The following is a description of a gene set: species: Mus musculus Any process leading to the attainment of the full functional capacity of a protein. Mouse Gene Set: GOBP_PROTEIN_MATURATION, and this is the list of marker genes: Thbs1, Klk13, Hspa8, Aasdhppt, Mme, Hspe1-rs1, Cpa3, Pfdn1 (prefoldin 1), Astl, Lias, Cuzd1, Fnta, Srgn, Fkbp8 (NCBI Gene Id 14232, FK506 binding protein 8), Lonp2, Pgap3, Atg4d, Prcp, Casp6, Prkacb, Ppic, Rnf123, Sec11a, Bag1, Hspb2, Ppp1r15a, Klk1b27, Usp17le, Snx12 (NCBI Gene Id 72081), Glrx3, Klk5, Slc30a8, Hsph1, Erp27, Prss57, Psenen, Plaur, Klk1b21 (NCBI Gene Id 16616), Tbcel (tubulin folding cofactor E-like), Fgg (NCBI Gene Id 99571), Dnajb4, Klk1b16, Ren1, Gzme, Cct5, Hgfac, Klk8, Timm23, Prdx4, Canx, Chchd4, Ppil1, Tfr2 (transferrin receptor 2), F12, Sde2, Asprv1, Pcsk4, Fuz, H2-DMb1, Serpinh1, Ppie, Bace2, ENSMUSG00000125816, C1ra, Hspa5, Rhbdd1, Dohh, Adam9, Ciao1, Actmap, Casp2, Pigs, Mipep (NCBI Gene Id 70478), Myc, Dnaja2, Ahsa2, Ace, Klk12, Naa20, Immp1l, Serpine2, Elp6, Hspa1l, Clec3b, Sprtn, Gas1, Serpinf2, Naa60, Pdcl3, Tspan17, Ppwd1, Aip, Plgrkt, Tcp1, Fgb, LTO1, Erp44, St13, Casp7, Lipt1, S100a10, Fam111a, Hspa4l, Mmp14, Dync2h1, Hspa13, Ncstn, Rps6ka2, Aebp1, Zmpste24, Metap1, Pigm, Tmprss9, Tsc1, Nfu1, Gm15441, Fga, F7, Ppih, Cct3, Eef1ece2 (Eef1akmt4-endothelin converting enzyme 2 readthrough), Glg1, Dnajb13, Pmpca, Lmf1, Nlrc4, Nudcd3, Ctss, Kat2b, Ccdc47, Cdc37l1, Yae1d1, Isca1, Ppil2, Klk14, Cpd, Dnajb1, Chst8, Mesd, Pcsk9, Atg4c, Nktr, Il1r2, Telo2, Clu, Pcsk6, Ppid, Nppa, Phex (NCBI Gene Id 237149), Naa10, Ppif, Vps35, Anxa2, Cd74, Bmp1, Zpr1 (NCBI Gene Id 22687), Ppig, Dnajc7, Sirt4, Spon1, Pigo, Tll2, Rp2, Ecel1, Pigc, Nudc, Tmem208, Mafb, Gzmn, Pigl, Naa11, Cwh43, Pfdn6, Nlrp3, Afg3l2, Clpx, Klk1b22, Casp4, Rnf139, Pdilt, Tbcb, B2m, Arxes2, Disp1, Flna, Cpz, Spcs1, Prkaca, Plau, Pfdn5, Tasp1, Dnajc2, Casp12, Dnaja4, Zmynd10, Sppl3, Gzmb (NCBI Gene Id 14939), Atg4a-ps, Tll1, Pcsk5, Myrf, Prss58, Calr, Spcs3, Apoh, Ift88 (intraflagellar transport 88), Hspa4, Cct6a, Ero1b, Gp1bb (NCBI Gene Id 14724), Hspd1, Bola3, Trap1, Aph1b (aph1 homolog B, gamma secretase subunit), Naa12, Ptges3-ps, Klk1b11, Dnajc25, Wdr83os, F13a1, Grpel1, Cdc37, Spg7, Unc45b, Pgap4, Arl2, Tspan15, Klk1b1, Klk1b4, Tescl, Tmprss4, Tor2a, Cpb2, Pex19, Cstl1, P2rx7, Hsp90b1, Meltf, Pigt, Rce1, Sdf2, Klk1b8, Qsox2, Aanat, Dnajb14, Gzmf, H2-DMa, Parp1, Tesc, Dnajc18, Mmp16, Dpm2, Gsdmd, Pigp, Tspan33, Ranbp2, Eno1, Pik3c3, Tmprss2, Naa15, Adam17, Pigu, Cpe, Pyurf, Mdm2, Xpnpep3, Gcsh (glycine cleavage system protein H (aminomethyl carrier)), Mcpt8 (mast cell protease 8), Pitrm1, Cpm, Plat, Ufsp1, Ric8a, Psen1, Pdcd5, Aph1c, Casp1, Ric8b, Entpd5, Tmprss12, Ihh, Ndufab1, Hid1, Klk10, Pigb, Anpep, Mcpt1, Atg4b, Mmel1, Pigk, Prss3b, Tmem98, F13b, Pigyl, Parl, Dnajc10, Ahsp, Ldlrad3, Ttc4, Cfd, Naglu, Mcpt9, Spcs2, Dnaja1, P4hb, Casp3, Fbln1, Enpep, Fkbp10, Pthlh, Gzma, Grn (granulin), Ace2, Sox4, Pcbp1, Ctsh, Pdcd5-ps, Casp8, Yme1l1, Mbtps2, Lgmn, Hspe1, Slc30a5, Hspa1b, Nppb, C1rb, Cpn1, Gzmd, Atp7b (NCBI Gene Id 11979), Ric3 (NCBI Gene Id 320360), Hspb6, Adam10, Pigx, Fkrp, Pofut2, Mms19, Tor1b, Mep1a, Cct4, Hsp90ab1, Eno1b, Calr4 (NCBI Gene Id 71031), Pdia3, Dpm1, Prss12, Pign, Inpp5b, Nudcd2, P3h1 (NCBI Gene Id 72188), Prss59, Dhh, Ep300, Pdia4, Tspan14, Aph1a, F3, Hspa9, Ambp, Klk9, H13, Sh3glb1, Mcpt4 (mast cell protease 4), Capn1, Dnlz, Comp, H2-DMb2, Fxn, Capn2, Klk6, Mvp, F9, Hspb1, Pdcl, Dnajb5, Cdk20, Vbp1, Dnajb2, Myrfl, Agr2, Bola2, Hp, Mbl2, Nkd2, Pcsk2, Arxes1, Tnp1, Dpm3, F11, Pigz, Dnajb12, Pigw, Ctsl, Pigq, Naa80, Yipf5, Hspa14, Pgap1, Kel, Tysnd1, Zng1, Ndufab1-ps, Atg4a, Naa50, Pigg, Adam19, Tbcc, Tnp2, Rnpep, Gli3, Ppil3, Gzmc, Piga, Tbca, Cct6b, Hyou1, Gp1ba, Dhcr24, Furin, Bag2, Pisd, Dnaja3, Stub1, Dnajb7, Aim2, H2bc1, Ctla2a, Dnajc3, Fkbp9 (FK506 binding protein 9), Chac1, Fkbp11, Ggcx, Ogt, Dnajb8, Ctsz, Myh9, Prss37, AK157302, Ikbkb, C2cd3, Lrrk2, Gsn, Ccbe1 (collagen and calcium binding EGF domains 1), Tbcd, Gpaa1, Ift52, Hspa1a, Dnajc1, Pfdn2, Ptges3, Gzmg, Klk4, Angptl8, Pmpcb, Klk1b5, Dnajb11, Crtap, Pcsk1, Ptges3l, Fkbp4, Bag5, Pdrg1, F8, Ubac1 (NCBI Gene Id 98766), Gp9, Cma1, Cct8, Fkbp2, Klk1, Sec11c, Atp23, Dffa, Hpn, Tor1a, Klk15, Cdh1, Gp5, Pdcl2, Stoml2 (stomatin (Epb7.2)-like 2), Tbce (tubulin-specific chaperone E), Cct8l1, Grpel2, Rap1gds1, Pigf, AU015836, Casp9, Vsir, Prph2, Tmem260, Mkks, Cdc123, Duoxa2, Tspan10, Cryaa, Sorl1, Fkbp6, Ube4b, Isca2, Corin, Adamts3, Adamts2, Cryab, Pcsk1n, Cct7, Lmf2, Ciao2a, Zdhhc5, Pgap2, Mbtps1, Ahsa1, Sdf2l1, Afg3l1, C1rl, Nppc, Prss51, Bace1, Lipt2, Ptch1, Snapin, Src, Ciao2b, Hjv, Ppia, Qsox1, Fmr1, Unc45a, Ift172, Dhps, Ctse, Hspa2, Dnajb6, Rfx4, Klk1b9, Calr3, Hsp90aa1, Pfdn4, Cisd1, Prf1, Pdia2, Galnt2 (NCBI Gene Id 14424), Sgta, Naa16, Cma2, Prep, Icmt, Ppib, F2, Clgn, Ece1, Dnajc5, Ctsg, Immp2l, Txndc5, Metap2, Cisd3, Notch4, Klk1b26, Pigh, Plg, Cln5 (NCBI Gene Id 211286), Ggt1, Klk11, Cct2, Klk7, Psen2, Crebbp, Mppe1, Gfer, Dnajb3, Cntn2, Pgk1, Tspan5, Pcbp2, Selenof, Pigv, Scg5, Ddi2, Chordc1 (cysteine and histidine rich domain containing 1), Zdhhc9, Cplane2, Rasal2, Atp6ap2, Oma1, Ctnnd1, Cwc27, Pdia5, Timm17a, Umod, Gzmk, Acp4, Klk1b3, Pcsk7, Pidd1, Klk1b24, Cln3, Mcpt2, Glrx5 (NCBI Gene Id 73046), Ins2, Klkb1, Shh, Fkbp5, Ero1a, Ece2, Serpine1, Gzmm, Itgb3